Given this list of marker genes Hesx1, Ctf1, Lifr, Il6st, Lif, here is a description of the gene set: studied in species Mus musculus The series of molecular signals initiated by the binding of a leukemia inhibitory factor to its receptor on the surface of a target cell, and ending with the regulation of a downstream cellular process, e.g. transcription. Mouse Gene Set: GOBP_LEUKEMIA_INHIBITORY_FACTOR_SIGNALING_PATHWAY